Given this list of marker genes HCCAT5, DCLRE1B, ZNF570, SIN3A, PLCH1, MTCO3P12, USH2A, ZNF346, ZNF425, DDX24, PPP1R12A, FOSB, CDK5RAP1, CAPS2, CPT1B, FAM83E, CCDC17 (NCBI Gene Id 149483), PCNX1, ZNF446, PTDSS1, FAM151B, PNRC1-DT, JPX, DNAJC1, NAT10, HSD17B4, CCNG2, PNRC1, UIMC1, MIR4512, SRP9, GRAMD1A, LINC02987, ZNF26 (zinc finger protein 26), LINC00662, BTN3A3, SLC39A2, SND1, NDST4, PSMC4, KCNK1, GLIPR1L2, IFT70B, RPL9P15, ZNF569, SNORA9B, WDR87BP, RN7SL521P, ASAP1, PYM1, SNAPC5, TPTEP2, INPP4B, PDE7A, ZNF398, MIR466, TP53RK, RPL31P43, TRIM3, NRDE2, PRPF40B, MIR4716, CDC14A, SLC9B1, MID2, DDX55, CERS5, RPP40, GALK2, CTNNB1, IFI27L1, LINC01596, RNF103, CYB5R2, C6orf118, CARD10, RAD17 (RAD17 checkpoint clamp loader component), DGKA, IRF5 (NCBI Gene Id 84729), DAZAP1, PRR15L, PLA2G6, TXNDC12, PLEKHG4, RNA5SP29, LEKR1, AK6, TOP3B, ENSG00000201502, FAM151B-DT, MTND5P11, BTF3L4, TATDN2, SNX25, ENSG00000258471, GULP1, RNF103-CHMP3, TAF9, here is a description of the gene set: from publication Yevshin I, Sharipov R, Kolmykov S, Kondrakhin Y, Kolpakov F (PMID 30445619) Human Gene Set: ZNF708_TARGET_GENES species: Homo sapiens Genes containing one or more binding sites for (ZNF708) in their promoter regions (TSS -1000,+100 bp) as identified by GTRD version 20.06 ChIP-seq harmonization.